The following is a description of a gene set: Mouse Gene Set: GOBP_L_ALPHA_AMINO_ACID_TRANSMEMBRANE_TRANSPORT The directed movement of L-alpha-amino acid across a membrane by means of some agent such as a transporter or a pore. species: Mus musculus, and this is the list of marker genes: Itgb1, Tnf, Slc11a1, Arg2, Slc7a1, Slc22a2, Slc1a3, Grm1, Slc17a6, Grik1, Epm2a, Slc17a7, Slc25a15, Slc7a3, Kcnj10, Slc1a4, Slc6a20b, Nat3, Ucp2, Slc7a6, Slc25a2, Slc43a1 (NCBI Gene Id 98836), Slc25a29, Slc7a8, Slc25a18, Arg1, Slc38a5, Slc6a20a, Slc25a12, Slc7a2, Slc1a5, Slc3a1, Slc38a2, Ctns, Slc7a5, Slc1a2, Slc17a8, Arhgef11, Slc1a7, Septin2, Slc66a1, Slc43a2, Slc1a6, Ttyh1, Ttyh2, Slc7a13, Slc38a1, Ttyh3, Arl6ip5, Slc47a1, Slc38a6, Cln3, Ace2, Slc3a2, Slc38a3, Per2, Slc25a26, Slc7a11, Psen1, Slc25a13, Slc38a4, Slc1a1, Slc25a22, Agt, Cln8, Slc15a4, Slc7a7, Ntsr1, Slc38a9, Arl6ip1, Cltrn